Given this list of marker genes JHY, FCAR, LMOD3, ANKRD11P2, SPC24, ERN1, PMAIP1, SC5D, S100A4, GRIPAP1, ZNF682, VPS41, GADD45B, BIRC3, TRPM6, ICA1, DCLRE1C, PILRB (paired immunoglobin like type 2 receptor beta), CCN1, FOSB, PER2, IL17RD, SPDYE6, RBM15, SULT1A3, FRMD6-AS2, PPP1R3C, IL10, CLDN1, ERAP2, RNU11, ZNF223, LRRFIP1, C2orf88, WDR74, H4C12, JMJD7-PLA2G4B, FAM181B, DTWD2, EVI5, BRICD5, NPIPB11, GLUL, PPP1R15A, FGFR3 (fibroblast growth factor receptor 3), TDP1, CXCL8, KCNMB4, MAPK8IP3, RBM3, PLXNB1, BCYRN1, CATSPER2, TMEM107, RPL10L, TRMT1, ANKRD11 (ankyrin repeat domain containing 11), LINC00243, COA8, SULT1A1, DMC1, MAFF (NCBI Gene Id 23764), GRB14, DDIT4, BHLHE40, DENR, ZNF486, CHAC1, POFUT1, ALB, H2AC6, FKBP14 (NCBI Gene Id 55033), H3C7, ZNF880, FOS, KIAA0408, CRCP, LIME1, MCMDC2, BLZF1, RPPH1, UPF2, SESN2, SSTR2 (NCBI Gene Id 6752), LDLR, H2BC8, CEP85L, PLIN5 (NCBI Gene Id 440503), CHRNA5, RECQL4, AKAP7, HSD17B7, PLA2G2D, ADM, DUSP1, UGP2, AOC4P, CEL, SHCBP1, TDG, TRIB3, MYO3B, CKAP2L, SEMA3E, ZNF219, PHAX, SREBF1, TAF13, FUT6, RASSF6, PTGR2, SBF1, CREB1, SLC5A8, RHBDL2, USP49, SLC4A5, EGR1, ZNF786, PPM1K, ST3GAL5, DDX51, GSE1, NLRP8, H3C14, CCBE1, LILRB1, ATF3, STK40, STC2, ENSG00000261335, CCDC86, KCNH6, CHST3, ANKRD30B, PRRG4, HAUS2, NDUFAF7, ARL16, ANKRD44, HSPA8, YTHDC1, NUBPL (NCBI Gene Id 80224), NPIPB3, RNF213, MTHFD2, RN7SK, RPS13, WHAMM, EID2B, CSRNP1, PDE4C, JUNB, SHROOM4, BLOC1S6, NUDT1, TBC1D32, KREMEN2, SOX9, ZNF69, H2AC8, EIF2AK4, CDKN1A, PVALB, LINC01720, SESN3, ZNF483, DEPTOR, CLASRP, PIK3R3, SCARNA9, FMC1, H3C1, INPPL1, SNORD55, ANKRD20A1, AVPI1, PIP4K2B, CYFIP2, H2BP1, ATP2B1-AS1, PLEKHS1, NPIPB13, NRDE2, RAX2, RGS12, RGS2, DDIT3, NISCH, SNORD13, NPIPB15, CSF2RA, NUTM2E, XYLT1, SULT1A2, ZNF750, ANKRD20A11P, CEP19, EXO5, CD68, SPTLC1, CARS1, BCAR3, CHKA, IFRD1, ZNF652, DHCR7, MIB2, CDK5RAP2, TNFSF15, VEGFC, RHOT2, VARS2, MBD4, RNF144B, TRIM13, HNMT, NOP56, DPP7 (NCBI Gene Id 29952), ACOT2, KITLG, RPS3, CASZ1, SPDYE1, FAM72C, PIDD1, ZNF114 (NCBI Gene Id 7667), ZNF557, RNU12-2P, ABCA7, MCM8, RNU6ATAC, DLGAP5, BEGAIN, SNAPC1, CDKN2AIPNL, FCGR3A, CCDC137, IL1A, SPIRE1, METTL21A, TUBGCP6, TSC22D3, AIRE, ZMAT3, MYRFL, SDHAP1, LEP, NPIPB12, SLC44A4, SLC35E1, ATF4, GPT2, FGD3, MRPL27 (mitochondrial ribosomal protein L27), MINDY1, ID2, ITPK1-AS1, ZNF503, SNORD25, PTP4A2, HYKK, PNPT1, XRCC2, OCIAD1, ZNF669, TDRD1, TACC3, H2AC17, PPA2, ID1, MORC2, KNTC1, ALPP, TNFSF14, N4BP2, CBX4 (NCBI Gene Id 8535), H4C2 (H4 clustered histone 2), SALL4, HMGCS1, PCDHB9, TMEM17, ZNF549, INPP5D, CFAP74, CMKLR2, ZNF394, H2BC3, MBTD1, HNRNPU, YRDC, ZNF14, TRPV6, ID3, CUL9 (NCBI Gene Id 23113), CPT1B, SERF2, WFIKKN1, ZNF577, CHTF18, here is a description of the gene set: from publication Jinesh GG, Kamat AM (PMID 28855211) Human Gene Set: JINESH_BLEBBISHIELD_TRANSFORMED_STEM_CELL_SPHERES_DN Apoptosis is a process that kills cells. However, cancer stem cells find ways to escape death after commencement of apoptosis. One such mechanism is blebbishield emergency program, in which the apoptotic cancer stem cells first undergo apoptotic body formation but then reassemble apoptotic bodies with main body (nuclei containing) of the apoptotic cells to form spherical to elongated structures called blebbishields. Blebbishields in turn are capable of blebbishield-blebbishield fusion to form transformed stem cell spheres (transformation phase) and then give rise to individual cancer cells from spheres (exit phase). We identified blebbishield emergency program in RT4 bladder cancer cells (RT4P=P stands for parental) and did microarray analysis of live RT4P cells, blebbishields and transformed spheres. This data set is a comparison of blebbishields with transformed spheres and the gene list includes the genes that are downregulated in transformed spheres. A separate set is provided for upregulated gene list too. In addition we provide separate gene lists for upregulated and downregulated gene lists for blebbishields compared to RT4 live cells. Genes Down-regulated in transformed spheres compared to blebbishields from RT4 cells studied in species Homo sapiens